Given this list of marker genes GSTM2, PRKAA1 (protein kinase AMP-activated catalytic subunit alpha 1), GNAL, RYR2, HDAC2 (histone deacetylase 2), SELENON, SLC8A1, CASQ2, ADORA2A, RYR1 (NCBI Gene Id 906), CAD, RYR3, TMEM38A, CACNA1S, TRPA1, TMEM38B, here is a description of the gene set: Human Gene Set: GOBP_RESPONSE_TO_CAFFEINE Any process that results in a change in state or activity of a cell or an organism (in terms of movement, secretion, enzyme production, gene expression, etc.) as a result of a caffeine stimulus. Caffeine is an alkaloid found in numerous plant species, where it acts as a natural pesticide that paralyzes and kills certain insects feeding upon them. species: Homo sapiens